The following is a description of a gene set: species: Mus musculus from publication Yevshin I, Sharipov R, Kolmykov S, Kondrakhin Y, Kolpakov F (PMID 30445619) Mouse Gene Set: MLLT3_TARGET_GENES, and this is the list of marker genes: 2610005L07Rik, Pid1, Eif5, Gm9887, Txn2, Armc8, Cyb5r4, Dusp2 (dual specificity phosphatase 2), Sp3, Ccnl1, Gm15787, Sash1, Rnu7, Arhgdia, H3c7, Ubc, Tnfaip2 (NCBI Gene Id 21928), Gm24453, Rpl3-ps1, Slfn10-ps, Rpl13, Ccnt1, Gabpb1, 4931440P22Rik, Canx, B4galt7, B130034C11Rik, H4c1, Hnrnph1, Tmem186, Cct8, Etf1, Zfp91, Rbm47, Stag2, Stamos, Ccdc86, Isy1, Kdm5a, BC005537, Sphk2, Arhgef2, Pcdh7, Rpl31, Atp6v1a, Vgf, Dennd6b, Kdm3a, Pdia6, A530013C23Rik, Thap2, Gm19710, Lcp2, Abhd12, Crebzf, Atp5f1c, Myc, Fra10ac1, Ppid (peptidylprolyl isomerase D (cyclophilin D)), Champ1, Mrpl21, Gm4189, Mettl6, Mrpl49, Dock10, Neat1, 5730420D15Rik, Zzz3, Pnrc2, Psmb3, Gm29083, Lrrfip1, Ufd1, Prkcd, Exosc4, Gm29340, Spink5, Parvg, Tmem242, A230028O05Rik, Rpl36al, Oxsr1, H2ac14-ps, H3c6, Eif5a, Mthfs, Zc3h15, Ubac2, Gm6209, Itga4, Mir1949, Stx16, Taf4, Top3a, Pex3, Ogt, Tor3a, Dleu2, Actb, Eif4a2, Gm38158, Gm16675 (NCBI Gene Id 100503498), Syncrip, Foxp1, Cpd, Pxk, Alyref2, Sdhaf2, Tnni2, Spred1, 4933440N22Rik, H2-T24, Maml3, Nsd3, Adrm1, 4931406C07Rik, Scrt1, Lrrc8d, Gm15459, Ggact, Gm13822, Wdfy3, Vipas39, Prpf38b, Gm15441, H4c9 (H4 clustered histone 9), Sass6 (SAS-6 centriolar assembly protein), Ttc41, Gm26205, Dcp1a (NCBI Gene Id 75901), Cdc45, Ss18, Lsm2, Ift56, Lnpep, Ptpn21, Zfp617, Fbxo36, H2ac13, Ccl2, Raly (hnRNP-associated with lethal yellow), Skil, Smox, Ighmbp2, Tmco1, Zmynd8, Septin11, Lif, Ubap2l, Tgs1, Lrrc41, Ikbke, Snord12, Rbpj, Rasgrp3, Srsf11, Zc3h7a, Helz2, Rab32, Ifrd1, Gm23201, H3c3, Zcchc2, Nup58, Dglucy, Stt3b, Dnajb4, Snora65, Gm27003, Flna, Tnf, Zbed4, Bcl2a1b, 1600020E01Rik, Slc6a12, H3c8, G730013B05Rik, Peds1, Polr3c, Comtd1, Ifit3b, Pik3r5, Ptma, Trmt112, Dhrs3, Fmc1, Vti1a, Traf7, Stx18, Dcakd, 2900005J15Rik, Rpl30 (ribosomal protein L30), Htr1b, Timm23, Aldoa (NCBI Gene Id 11674), Wtap, Oxsm, Snora21, Elk4, Trip12, Ncbp3 (NCBI Gene Id 97706), Tnfaip3, Slc2a1, Nme1, Gm24494, Rps5, Snord78, Gm11959, Gm38293, Krr1, Cdt1, H2bc8, Ssbp1 (NCBI Gene Id 72790), Jmjd1c, Snora61, Lrp6, Fosl2, Ift80, Prdx5, Htra2, Trmt1l, Adam15, Tln1, Tefm, Rps4x, Mdh2, H1f4, Rapgef2, H2bc18, H2bc15, Gm24016, Haus8, Rpl27a, Irf2bp2, Rsrc2, Aebp2, Lrrc40, Cnih4, Mrpl12, Hsp90ab1, Snx17, Mir22hg, Etv3 (ets variant 3, NCBI Gene Id 99611), Zfc3h1, 2510009E07Rik, H3c15, Fem1c, Slc15a4, 9230114K14Rik, Gtf2b, Slc25a5, Gm16740, Xaf1, Zfp710, Crlf3, Tsacc, Dus2, Inpp5d, Anp32e, Cxcl10, Tfdp1, Bms1, Rrp15, Gm5447, Trmo, Snord15a, Pcna, Ldha, Mir142, Rps27, C130036L24Rik, Csf1r, Gm15473, Pabpc1, H3c13, Spty2d1 (NCBI Gene Id 233218), Notch2, Pfn1, Pan2, Snord14a, Apbb2, 5730455P16Rik, Zfp36l2, Mgat2, Gtf2a1, Gm43403, Cebpb, Snora16a, Gm23246, Zfas1, Nop56, H2ac6, Apobec1, Mir1893, Tti2, Ythdf3, Hexim1, Mir1932, Mrpl1, Gm25296, Hspa8, Ikzf1, Tacc3, Zc3h12a, Gm22711, Tpm1, Prpf19, 2610020C07Rik, 4930524O07Rik, Id3, H3f3b, Rps15a, Fndc3a, Zc3h4, Dpp9, 0610039K10Rik, Ncor1, Snrnp70, Rbm39, Brpf1, Gm13470, Gm23130, Snord68, Rhbdd3, Chtop, Oxct1as, Hoxa1 (homeobox A1), Rgs2, Klf7, Fbxo11, Rpl23a, Hivep2, Usp18, Glra1, C920006O11Rik, Mcee, Cd47 (CD47 antigen (Rh-related antigen, integrin-associated signal transducer)), Slc38a1, Rps21, Pbld2, Kpna2, 1110019D14Rik (NCBI Gene Id 76311), Phf11d, Slc25a28, Tal1, Gm16283 (NCBI Gene Id 102635853), Stom, Jak2, Nadk, Gm17690 (predicted gene, 17690), Usp3, Kpnb1, Ewsr1, Gm15420, Snord58b, Zfp106, Slc31a2, Parp10, Mapk6, Gpatch4, Fam53c, Rpl18, Norad, Hspa5, Ube3a, Hnrnpa3, Birc2, D16Ertd472e, Gm24044, Zmiz1, Sugct, Snora33, Ndufaf3, Slc20a1, Gm16759, Flcn, Gm25789, Lactb2, Slc4a1ap, Cap1, Sp140l2, Stambpl1, Nav2, Anp32a, Mapk8ip2, Snx12, Zfp263, Rpl35, Gm23301, Zfp62, 6820431F20Rik, Cybb, Coro1a, Tm2d2, H2bc3, Krcc1, Dnaaf9, Casp8 (caspase 8), Mycn, Arap1, Tent4a, Ptch1, Eif4a1, Tbrg4, P4hb, Tet2, 1600023N17Rik, Pigl (NCBI Gene Id 327942), Tmem129, Isca2, Ncf1, Tpt1, Jarid2, Zc3h12c, Rps12, E030042O20Rik, Ttc39d, Gm11335, Zfp568, Capg, Bcl6, Ubqln4, Fth1, Gm7160, 4930594M22Rik, Snord52, Irf5, Asxl1, Alkbh1, Gm24524, Mrps18c, Stam, Oard1, Cul4a, H3c2, Rpl24, Cep57, Rad54l2, Gm15471 (NCBI Gene Id 100503157), H3c11, Peak1os (NCBI Gene Id 102633516), Gm8000, Socs2, H2az1, Ptgs2os2, Tex30, Obox4-ps39, Nfkbid, Blvra, Tdrd3, H2ac18, Spp1, Gm11696, H2bc13, Vmp1, Cdkl4, Rpl28, Hnrnpk, Ints10, Mtf2, Snora26, Kmt2a, Mllt11, Rps18, Mthfsl, Cnot7, Cct5, Ino80d, Ilk, Kmt2e, Hnrnpd, Gm22589, Prkacb, Smg7, A530040E14Rik, 9130024F11Rik, Ube2j2, Epc1, Cxcl16, Gm10602 (predicted gene 10602), Pigq, Gng5, Ino80dos, Cox7c, Gart, Cldn12, Gm26885, Zeb2os, Supt7l, Ostf1, Fam72a, Bcl2l1, Mbnl1, Mndal, Rpl15, Cab39, Ywhaz, Hnrnpu, Bcl2a1d, Snord47, Rpl9, Kri1, Tcerg1, Xbp1, Snord13, Ywhae, Sh3bp5, Nfat5, Pdgfb, B3galt6, Isg15, Usp1, Gorasp2, Tcf12, Rpl3, Gm13483, Gas5, Rabggtb, Evi2a, Gm26511, Mtdh, Phb2, Aurka, Eapp, H2ac15, Frmd8os, Poldip3, 4632427E13Rik (RIKEN cDNA 4632427E13 gene), Spata1, H2ac4, Hspd1, Susd6, Cx3cr1, Uchl5, Snora7a, Mapkbp1, Bend3, Cyb5r1, Apbb1ip, Ddx24, Zc3h10, Zeb2, Cdk14, Mir425, Creb1, Resf1, Strbp, Gm26448, Tmed2, Rpl10a (ribosomal protein L10A), H1f3, Taf6l, Nabp1, Ifi207, Sec14l1, Synj1, Septin10, Manf, Nkiras1 (NFKB inhibitor interacting Ras-like protein 1), Chd2, Tex14, Brd2, Gm29707, Srsf9, Zfp407, Lias, 1810009A15Rik, Rrp8, Nfkbil1, Tnpo1, Ppp2r1a, Lyz2, H2ac7, Gm7008, Parp14, Snord2, Pcbp1, Mir3091, Oas1c, Tapbp, Lamtor2, Ssrp1, Dpp8, Arid1a, Lrrc25, Tor1aip1, Son, Gm6345, Morf4l2, Arf4os, Rps25, Ints12 (integrator complex subunit 12), A430057M04Rik, Ddx21, Rsrp1, Pcid2, 4930583K01Rik, Fam227b, Abr, Atp2a2, Tmem68, Nipa2, Themis2, Gm26728, Ythdf2, Ndufc2, Mbtps2, Gm5106 (NCBI Gene Id 330031), Sfpq, Srsf2, Eif1, Mgme1, Msh5, H2bc22, Snhg12, Malat1, Eif4e2, Mir1938, Gm23212 (NCBI Gene Id 115487644), Lpcat4, Wnk1, Mex3c, Rpl12, 4933433G15Rik, Pafah1b1, Gramd1a, Rpl10, H2bc7, Gm11999, B3gnt2, Lamtor1, Usp34, Trmt13, Creld1, Ell2, Mrpl39, Myo10, Prkag2, Gm10501, Slc39a6, Akr1a1, Sgms1os1, Gusb, Mtg1, Naa15, Rpl11, Hnrnpa2b1, Chmp6, H2ac11, Zfp560, Mir7b, 1700041G16Rik, Mfsd11, Mplkip, Rpl35a, Snora44, Polr1h, Fubp1, Tlr6, Ints5 (NCBI Gene Id 76328), Polr2a, Txnip, AA386476, Gm22680, A230056P14Rik, Nmrk1, Gm23639, Atrn, Cnpy3 (NCBI Gene Id 73685), Ccdc77, Snord110, Hax1, Styxl1, Eef1g, Dr1, Gabarap, Plekha2, Edc4, Chaserr, Galnt7, Ptgs2os, Clic4, Arsg, Alcam, Slirp, Rplp0, Ccl9, Rps14, Nprl3, Chordc1, Dcaf10, Zfhx4, Pbx3, Noc2l, Ythdc1 (YTH domain containing 1, NCBI Gene Id 97542), Dusp4, Tgfb1, H4c3, Rps20, Tcof1, Mmadhc, Grcc10, Ppia, Rps10, Fgr, Hyou1, Nr3c1, Sdf4, Rbbp6, Ipo7, Adnp, Tbc1d7, 2500004C02Rik, Tmed7, Snord82, 2410002F23Rik, Tbl1xr1, Snord35b, Eif2b4, Sh3bp2 (SH3-domain binding protein 2), Galk2, E2f3, Snora52, Pkn3, H2ac22, Sec22b, Tspoap1, Runx1, Sf3a2, Snora17, Cfap298, Rbm3os, Mir191, Psmd3, Gapdh, Gm33370, Cltc, 5031425E22Rik, AF357399, Snhg15, Gnb1, Swt1, Ftl1, Vars1 (valyl-tRNA synthetase 1), Nup54, Tlcd2, H4c18, Il1b, Tma16, Zfp335, Pten, Tfrc (transferrin receptor), Asph, H2ac19, Snord80, Il27, Gm24067, Med13, Slfn3, Ndufs1, Rigi, Gm30238, Plekhm3, Hoxb7, Gm10382, Uba52, Taf1b (NCBI Gene Id 78429), Gm11613, Rps2, Cnot6l, S100a6, Zmynd15, A730017L22Rik, Gsk3b, Fau, Snord83b, Kin, Trex1, Icam1, Gm26608, Hsp90aa1, Gm27017, Atp6v1d, Tomt, Man1a2, Mrps21, Eno1, Helq, Parp12, Dennd2d, Mir6935, Sirpa, Elp2, Psmg3, Scd2, Parg, Hcst, Arl14ep, E130317F20Rik (RIKEN cDNA E130317F20 gene), 4930532G15Rik, Herpud1, Cdc42se1, H2bc11, Rpl37a, Zdhhc6, Atp6v1g2, Snora3, Ppp4r3b, Eif2d, Arhgef1, Or9g20, Ctbp2, H3c4, Snord45c, Snhg9, Rps17, Fxyd5, Zfand5, Dusp16, Cbx3, Cdk6, H2-K1, Epb41l4aos, Snora78, Tbpl1, Calm2, Isg20, Vdac2, Dpy19l4, Cacng2, 2300009A05Rik, Tmem222, Fgfr2, Sh2b3, 1700045H11Rik, Gm22107, Lrsam1, Calu, H2ac8, Fam53a, Opa3, Tubb5, Rpl21, Zfp142, Atf3, Mphosph10, Plekho1, Rnf115, Shisa5, Rpl30-ps6, Ctnnb1, Nlrp3, Snord42b, Mttp, Mir3569, Gm23969, Hint1, Kmt2b, Aup1, Sik3, Cyth4, Pofut1, H2bc6, Zbtb7a, Set, Ttc14, Midn, Prdx1, Bola1, Ywhah, Kbtbd2, Cdk12, Rbpms, Nsun3, B4galnt1 (beta-1,4-N-acetyl-galactosaminyl transferase 1), Hdgf, H4c6, Iqcg, Hspe1, Satb2, Snord65, Fam76b, Snord43, Dusp1, Zfp994, Golga3, Clhc1, H2ac5-ps, Bcl2a1a, Dgkz, Oas1a, Ppm1h, Gm42918, H2ac12, Atg9b, Snhg6, Flot1, AV099323, Tsc1, Eif2a, Usp53, Gtf3c6, Ccnl2, Snrpa, Rcc2, Baz2b, Gm22879, Tor1aip2, 4933434E20Rik, Mapkapk2, Slc39a9, Hotairm1, H2bc26, Mov10, Haspin, Gm13523, Isca1, Nuf2, Rsad2, Slc9a1, Ro60, Slc39a13, Eef1a1, Jpx, Mir1894, Gm11398, Trmt10c, Klhl35, Ino80b, Atg101, Slfn2, Phlda1, Ing2, H2bc21, Mir5122, Fbxo48, Hck, Tob2, Gm13283, Phc2, P4ha1, Bcs1l, Rpl27, Ptgs2, Pigv, Smim30, Socs1, Rplp2, Pgghg, Nelfa, Atxn7l2, Laptm5, Etv1, Actg1, Med22, Cxcl11, Gm22748, Slc35b2, Mef2c, Rpl22, Cct3, Nrros, Rpl6, Mdc1, Glipr1, A430105J06Rik, Nsun2, Dab2, Sh3tc1, C920021L13Rik, Luc7l, 4930599N23Rik, Ccnd1, Polr1has, Rpl5, Gm19412, Trib1, Taf15, Rpl18a, Gm4285, Aaas, Phip, Hmg20a, Rpl36a, H4c12, Rps29, 0610009L18Rik, Zbtb11, Rps23, Syvn1, Pmm2, Hmgb2, BC065397, Snhg7os, Mtif2, Peli1, Rps19, H3c1, 9530068E07Rik, Snora64, Gm22744, Insr, 1110038B12Rik, Exoc2, Eldr, Ankrd13c, Aldh7a1, Rmi1 (NCBI Gene Id 97878), Slc1a5, Siglec1, Myl12b (NCBI Gene Id 98057), Rab30, Gm9903, Nvl, Kntc1, Myo1c, Rpl7a, Sgms1, Prpf8, Atxn7, Ppp1r15a, Stap1, Rps9, Ap5b1, Adam17, Rab13, Atpsckmt (NCBI Gene Id 68073), H3c10, Rps27a, Gm20652, Irf2, Tgif1, Smim14, Hexim2, Gm2673, Vps52, Cep95, Gm3807, Gm25878 (predicted gene, 25878), Edem1, Slc38a2, Srsf7, Mapkapk5, Sinhcaf, H2bc12, Pik3ap1, Gstcd, Ctu1, Mir21a, Eif4g2, Gm8818, Zup1, Pura, Thumpd3, Ddx39b, 1810041H14Rik, Aff1, Trp53rka, Kmt2d, Akap13, Znfx1, Ccni, Trappc4, Bbc3